Given this list of marker genes Dnmt3l, Pagr1a, Dnajb6, E2f7, Tmed2, Map3k4, Paxip1, E2f8, Fzd5, Ascl2, Htra1, here is a description of the gene set: Mouse Gene Set: GOBP_CHORION_DEVELOPMENT species: Mus musculus The biological process whose specific outcome is the progression of a chorion from an initial condition to its mature state. This process begins with the formation of the structure and ends with the mature structure. The chorion is an extraembryonic membrane.